Given this list of marker genes ATP8A2, IRF4, EHMT1, IL1RL1, PANX1, CRACDL, PHLPP1, PIK3CB, PDE8A, GGN, KCNK6, CLDND1, CCL4, CYP4F22, PLAUR, DOT1L, CBX5, ASPG, SDF2L1, MCF2L, TIMELESS, ARL3, PHACTR3, ASAP2, PMEPA1, DCBLD2, CD320, PER1, PTPRE, APPBP2, ANXA11, FXYD2, RYR1, RTN4RL1, FRMD6, ZDHHC18, ASB11, APBB2, FXYD5, OSM, IGF2BP2, C1orf21, ITGA5, SATB1 (NCBI Gene Id 6304), BEST2, ANXA3, DLG3, RELB, ATP5MC3, GPR68, SLC7A11, PDPN, GASK1B (NCBI Gene Id 83936), POSTN, CNNM2, CRLF2, RASAL1, RUSC2, FEM1B, MAP2K4 (mitogen-activated protein kinase kinase 4), ITSN1, PRELID2, DUSP28, NANOS1, NTRK1, IFITM3, ACAP1, CRTAP, PPARG, ETS2, CRELD2, ABI2, FOXRED2, PLEKHA1, AMN1, CTTN (NCBI Gene Id 2017), AHI1, SPRYD7, DENND11 (DENN domain containing 11), PRDX4, NES, PTPRS, SPNS3, FAM118A, DPYS, MMP8, CFAP54, SLC2A6, TPR (NCBI Gene Id 7175), DEF6, ZNF516, NNMT, DPYD, SPSB4, INPPL1, THPO, SMDT1, KIAA0319, TTC39C, LRRC8C, FGL2, CAPN6, SAMSN1, DAPK1, FAM217B, CSNK2A2, MMP12, MALT1, CLSTN1, ABCC1, GCHFR, LPCAT2, RNASET2, FAM43A, GCLM, CD40, CHST11, SMAD7, LONRF3, TLR1, STXBP1, CDKN1A, DLGAP4, CLCN5, RTKN, PCDHB11, SS18L2, MTF2, FABP3, TIMP2, PTPN9, CDCP1, SPP2, MYBPH, SMPDL3B, STAP1, ATP1B3, NFKBIE, ZC3H12C, ARPC2, PFDN1, MRPL48, LPGAT1, FOXB2, CNNM4, FN1, XKR4, TNFAIP3, PSD3, PILRB, RILPL1, TRAF3, TMEM163, TESK1 (testis associated actin remodelling kinase 1), NCF1, FHOD1, KCTD17, PRKD3, CD14, ARL4C, CRMP1, NTHL1, IL21R, TENM4, GSS, ARHGAP6, CD276, CD163, TACC2, C18orf54, EMC10, ITGAX, RGS16, MMP14, TMED3, STON2, MARCHF1, MMP9, PRKCB, RUNX3, SQOR, TMEM171, KLK8, ZYX, TSPAN13, KLF6, MFSD6, AGPAT2, FLNC (NCBI Gene Id 2318), GABRA3, P3H3, JARID2, SPMIP5, DCSTAMP, UCHL5, SPHK1, ADGRG6, UCHL1, PLAGL1, VOPP1, here is a description of the gene set: studied in species Homo sapiens Genes up-regulated in bone marrow-derived macrophages at 45 min of stimulation by IL10 and LPS: IL6 knockout versus IL10 knockout. IL-10 or IL-6 stimulation of control 129xC57BL/6 murine bone marrow derived macrophages in the presence of LPS. We used microarrays to detail the global programme of gene expression changes in response to IL-6 or IL-10 stimulation in the presence of lipopolysaccharide. BMDMs were isolated from control, IL-6-/-, and IL-10-/- mice on a 129XBL/6 mixed background mice and differentiated in the presence of CSF-1 for 6-7 days. Cells were scraped and plated in 6 well plates at 2x10e6/well. Cells were washed with complete DMEM and rested for 1-2 hr before stimulation with combinations of IL-10 (10 ng/ml), IL-6 (2 ng/ml) or LPS (100 ng/ml) for 45 min or 180 mins. Complete biological replicates were performed. Human Gene Set: GSE5589_IL6_KO_VS_IL10_KO_LPS_AND_IL10_STIM_MACROPHAGE_45MIN_UP from publication El Kasmi KC, Holst J, Coffre M, Mielke L, de Pauw A, Lhocine N, Smith AM, Rutschman R, Kaushal D, Shen Y, Suda T, Donnelly RP, Myers MG Jr, Alexander W, Vignali DA, Watowich SS, Ernst M, Hilton DJ, Murray PJ (PMID 17114459)